The following is a description of a gene set: species: Mus musculus Mouse Gene Set: GOBP_ANDROGEN_RECEPTOR_SIGNALING_PATHWAY A nuclear receptor-mediated signaling pathway initiated by an androgen binding to an intracellular receptor of the nuclear receptor protein family, and ending with regulation of a downstream cellular process, e.g. transcription., and this is the list of marker genes: Mapk1, Ube3a, Usp26, Cst11, Rnf6, Smarca4, Ar, Zmiz1, Ddx17, Zbtb7a, Daxx, Scgb2a2, Dab2, Ddx5, Arid1a (AT-rich interaction domain 1A), Kdm4c, Ncor1, Safb, Prmt2, Zdhhc7, Igf1, Esr2, Nodal, Fkbp4, Rwdd1, Rhoa, Pten, Tcf21, Kdm5d, Ep300, Heyl, Sirt1, Pias2, Phb1, Nkx3-1, Park7, Safb2, Foxp1, Hdac1, Tmf1, Shq1, Kdm3a, Ncor2 (NCBI Gene Id 20602), Sfrp1, Foxh1, Rnf14, Dnaja1, Trim68